Given this list of marker genes SET, BRAF, NF1, RBBP8, TRIP13, RFX7, GNB2, here is a description of the gene set: Human Gene Set: HP_FEW_CAFE_AU_LAIT_SPOTS Few cafe-au-lait spots The presence of two to five cafe-au-lait macules. studied in species Homo sapiens